Given this list of marker genes NAGA, ELMO2, NHP2, SEMA4D, ARX (aristaless related homeobox), ARL6IP6, LMNA, HLA-DRB1, DDB2, CAST (NCBI Gene Id 831), PCNA, CCN2, ABCC6, TMC6, NPM1, RTEL1, KIT, GNPTAB, IARS2, TERC, CAV1, ARPC4, TERT, FERMT1, GLA, ENG, DKC1, SLC2A10, NF1, LIG4, POLE, XPC (XPC complex subunit, DNA damage recognition and repair factor), IKBKG, ATM, VPS53, ATR, CCR6, TTI1, MST1, KIAA0319L, ATRX, LBR, PORCN (NCBI Gene Id 65017), IL7, XRCC4, GNA11, WRAP53, CIB1 (NCBI Gene Id 10519), WNT10A, SLC29A3, SLC37A4, WRN (NCBI Gene Id 7486), XPA (NCBI Gene Id 7507), ERCC5, PARN, ERCC3, ACVRL1, GDF2, TYMS, CYLD, NOP10, USB1, IRF5, SMAD4, TMC8, ANTXR2, SDHD, COL3A1, ERCC4, TCF4, PIK3CA, CTC1, SOX18 (NCBI Gene Id 54345), TINF2, ENPP1, GPR35, POLD1, ERCC2, BLM (NCBI Gene Id 641), here is a description of the gene set: Presence of small, permanently dilated blood vessels near the surface of the skin, visible as small focal red lesions. Human Gene Set: HP_TELANGIECTASIA_OF_THE_SKIN studied in species Homo sapiens Telangiectasia of the skin